The following is a description of a gene set: studied in species Mus musculus Mouse Gene Set: GOBP_NEGATIVE_REGULATION_OF_POTASSIUM_ION_TRANSMEMBRANE_TRANSPORTER_ACTIVITY Any process that stops, prevents or reduces the frequency, rate or extent of potassium ion transmembrane transporter activity., and this is the list of marker genes: Kcnq1, Actn2, Kcne3, Kcne2, Stk39, Ank3, Oxsr1, Sumo1, Cav1, Casq2, Kcnrg, Kcne1, Agrn, Kcnab1, Grp, Nedd4l, Crbn